Given this list of marker genes PPA2, HMGB1, CCZ1 (CCZ1 homolog, vacuolar protein trafficking and biogenesis associated), CNOT9, SELENOT, MSH2, USP15, NOLC1, SRRM1, BUB3, HSDL2, STK17A, MED21, CSTF3, OSGEPL1, TUBGCP5, SNX5, IFNAR1, PEG10, EZR, CCNG2, ACTB, AMD1, ZNF207, SLC39A6, CCNC, CPE, MRPL42, HMMR, LAPTM4B, C4orf3, SNX10, DDX11, GNPDA2, ZNF585A, CYCS, PSME3, KPNA1, SRSF7, CDK1, PLSCR1, YWHAQ, TMTC4, ADPGK, SLC30A5 (solute carrier family 30 member 5), DLX5, S1PR5, NDC1, STMP1, DDOST, PROX1 (prospero homeobox 1), ALDOB, TMEM50B, RPL15, PCID2, here is a description of the gene set: The small molecular inhibitor MK886 is known to block 5-lipoxygenase-activating protein ALOX5AP and shows antitumor activity in multiple human cell lines. The broad antitumor therapeutic window reported in vivo for MK886 in rodents supports further consideration of this structural class. Better understanding of the mode of action of the drug is important for application in humans to take place. Affymetrix microarray study was conducted to explore MK886 pharmacologic mechanism. Ingenuity Pathway Analysis software was applied to validate the results at the transcriptional level by putting them in the context of an experimental proteomic network. Genes most affected by MK886 included actin B and focal adhesion components. A subsequent National Cancer Institute-60 panel study, RT-PCR validation followed by confocal microscopy, and Western blotting also pointed to actin B down-regulation, filamentous actin loss, and disorganization of the transcription machinery. In agreement with these observations, MK886 was found to enhance the effect of UV radiation in H720 lung cancer cell line. In light of the modification of cytoskeleton and cell motility by lipid phosphoinositide 3-kinase products, MK886 interaction with actin B might be biologically important. The low toxicity of MK886 in vivo was modeled and explained by binding and transport by dietary lipids. The rate of lipid absorbance is generally higher for tumors, suggesting a promise of a targeted liposome-based delivery system for this drug. These results suggest a novel antitumor pharmacologic mechanism. Human Gene Set: MAYBURD_RESPONSE_TO_L663536_DN Genes down-regulated in H720 cells (lung cancer) after treatment with L663536 (MK886), an inhibitor of leukotriene biosynthesis. species: Homo sapiens from publication Mayburd AL, Martlínez A, Sackett D, Liu H, Shih J, Tauler J, Avis I, Mulshine JL (PMID 16551867)